Given this list of marker genes CCNE1, PTGES, MAG, SOWAHD, ISM2, MYCN, SEMA4C, PDE6H, STAB2, EGFR-AS1, HEXB, KLRG2, FAM43B, AOC1, PRG2, FAT2, KISS1R, DIO2, HTRA4, RN7SL810P, WFDC3, ASAP3, CILP2, LINC01819, HSPG2 (NCBI Gene Id 7796), PYCR1, LINC00330, HLA-G, CERCAM, COL17A1, LAIR2, GKN1, MYCNUT, PTPRF, BEST3, GPR78, HTRA1, ASCL2, LY6D, ITM2B, PTPRQ, NOG, TNNI2, MYCNOS, GPR146, NOS2, TAC3, SLC17A8, AADACL3, POMC, LDLRAD2, KCNJ15, SYT8, NOTUM, RTN4RL2, CLDN19, LVRN, IGFL2-AS1, RNF223, FSTL1, LY6K, TNFSF10, FSTL3, DAW1, ASPSCR1, QSOX1, FN1, KCNK12, DEPDC7, KRT16P6, here is a description of the gene set: The gene expression program underlying the specification of human cell types is of fundamental interest. The study authors generated human cell atlases of gene expression and chromatin accessibility in fetal tissues. For gene expression, the study authors applied three-level combinatorial indexing to >110 samples representing 15 organs, ultimately profiling ~4 million single cells. The study authors leveraged the literature and other atlases to identify and annotate hundreds of cell types and subtypes, both within and across tissues. Our analyses focused on organ-specific specializations of broadly distributed cell types (such as blood, endothelial, and epithelial), sites of fetal erythropoiesis (which notably included the adrenal gland), and integration with mouse developmental atlases (such as conserved specification of blood cells). These data represent a rich resource for the exploration of in vivo human gene expression in diverse tissues and cell types. Human Gene Set: DESCARTES_FETAL_PLACENTA_EXTRAVILLOUS_TROPHOBLASTS from publication Cao J, O'Day DR, Pliner HA, Kingsley PD, Deng M, Daza RM, Zager MA, Aldinger KA, Blecher-Gonen R, Zhang F, Spielmann M, Palis J, Doherty D, Steemers FJ, Glass IA, Trapnell C, Shendure J (PMID 33184181) studied in species Homo sapiens Marker genes curated from the annotated cluster as represented in the Descartes Human Gene Expression During Development database.